Given this list of marker genes RBBP5, POLR3E, FMC1, AGBL5, CDK5RAP3, ALOXE3, RMRP, FMC1-LUC7L2, CCDC107, LTA4H, B4GAT1-DT, B4GAT1, LRP3, AGBL5-AS1, DPP9, here is a description of the gene set: Human Gene Set: WRN_TARGET_GENES Genes containing one or more binding sites for (WRN) in their promoter regions (TSS -1000,+100 bp) as identified by GTRD version 20.06 ChIP-seq harmonization. from publication Yevshin I, Sharipov R, Kolmykov S, Kondrakhin Y, Kolpakov F (PMID 30445619) species: Homo sapiens